Given this list of marker genes Tubb3, Msx1, Dcx, Pax6, Nes, Zic1 (zinc finger protein of the cerebellum 1), here is a description of the gene set: studied in species Mus musculus Mouse Gene Set: TESAR_ALK_TARGETS_EPISC_4D_UP from publication Tesar PJ, Chenoweth JG, Brook FA, Davies TJ, Evans EP, Mack DL, Gardner RL, McKay RD (PMID 17597760) The application of human embryonic stem (ES) cells in medicine and biology has an inherent reliance on understanding the starting cell population. Human ES cells differ from mouse ES cells and the specific embryonic origin of both cell types is unclear. Previous work suggested that mouse ES cells could only be obtained from the embryo before implantation in the uterus. Here we show that cell lines can be derived from the epiblast, a tissue of the post-implantation embryo that generates the embryo proper. These cells, which we refer to as EpiSCs (post-implantation epiblast-derived stem cells), express transcription factors known to regulate pluripotency, maintain their genomic integrity, and robustly differentiate into the major somatic cell types as well as primordial germ cells. The EpiSC lines are distinct from mouse ES cells in their epigenetic state and the signals controlling their differentiation. Furthermore, EpiSC and human ES cells share patterns of gene expression and signalling responses that normally function in the epiblast. These results show that epiblast cells can be maintained as stable cell lines and interrogated to understand how pluripotent cells generate distinct fates during early development. Genes up-regulated in EpiSC cells (epiblast stem cells) after treatment with the ALK inhibitor SB-431542.